Given this list of marker genes TLR3, HSP90B1, LGMN, TLR9, TLR7 (NCBI Gene Id 51284), CTSK, CTSS, UNC93B1, CNPY3, TLR8 (toll like receptor 8), CTSB, CTSL, CTSV (NCBI Gene Id 1515), here is a description of the gene set: part of: Toll-like Receptor Cascades Mammalian TLR3, TLR7, TLR8, TLR9 are endosomal receptors that sense nucleic acids that have been released from endocytosed/phagocytosed bacteria, viruses or parasites. These TLRs have a ligand-recognition domain that faces the lumen of the endosome (which is topologically equivalent to the outside of the cell), a transmembrane domain, and a signaling domain that faces the cytosol.<p>Under normal conditions, self nucleic acids are not recognized by TLRs due to multiple levels of regulation including receptor compartmentalization, trafficking and proteolytic processing (Barton GM et al 2006, Ewald SE et al 2008). At steady state TLR3, TLR7, TLR8, TLR9 reside primarily in the endoplasmic reticulum (ER), however, their activation by specific ligands only occurs within acidified endolysosomal compartments (Hacker H et al 1998, Funami K et al 2004, Gibbard RJ et al 2006). Several chaperon proteins associate with TLRs in the ER to provide efficient translocation to endolysosome. Upon reaching endolysosomal compartments the ectodomains of TLR7 and TLR9 are proteolytically cleaved by cysteine endoproteases. Both full-length and cleaved C-terminus of TLR9 bind CpG-oligodeoxynucleotides, however it has been proposed that only the processed receptor is functional.<p> Although similar cleavage of TLR3 has been reported by Ewald et al 2011, other studies demonstrated that the N-terminal region of TLR3 ectodomain was implicated in ligand binding, thus TLR3 may function as a full-length receptor (Liu L et al 2008, Tokisue T et al 2008).<p> There are no data on TLR8 processing, although the cell biology of TLR8 is probably similar to TLR9 and TLR7 (Gibbard RJ et al 2006, Wei T et al 2009). Reactome Pathway: Trafficking and processing of endosomal TLR studied in species Homo sapiens